The following is a description of a gene set: Duplication of renal pelvis A duplication of the renal pelvis. species: Homo sapiens Human Gene Set: HP_DUPLICATION_OF_RENAL_PELVIS, and this is the list of marker genes: H19, POU6F2, DIS3L2, KCTD1, SLC6A17, BRCA2, WT1, REST, TRIP13, ZEB2, TRIM28, GPC4, GPC3 (glypican 3)